The following is a description of a gene set: Genes in the cancer module 509. species: Homo sapiens Human Gene Set: MODULE_509, and this is the list of marker genes: FDFT1, IDI1, AP1S2, AP3S1, HPCAL1, SQLE, AP2S1, HPCA, TUBA4A, SEC24D, FDPS, LRP8, AP2A1, TUBB4B